Given this list of marker genes Fut9, Nkapl, Kalrn, Pan3, Pou3f2, Thoc1, Eif1ad19, Slc5a3, Pkp1, Pcmtd1, Srek1, Xlr, Clcf1, Gm20604, Sra1, 4933434E20Rik, Rap2c, Zdhhc21, Orc4, Arhgap20, Rlim, Ctdp1, Socs7, Dusp2, Nudt11, Foxo1, Asrgl1, Slc39a14, Bicd1, Atp2a2, Megf10, Sgms1, Stxbp1, Fbxw28, Rap1gap2, Zfp367, Taf3, Slc35g2, Gkap1, U2surp, Rai14, Slc26a4, Cadm1, Sntg1, Cuedc2, Lrp2bp, Tenm4, Tmem260, Speer4a2, Vamp4, C1d, Wdr1, Galnt3, Nfe2l2 (nuclear factor, erythroid derived 2, like 2), Gucy2c, Dynlt3, Gpbp1, Slc30a4, Birc6, Pclo, Nipsnap1, Abi1 (NCBI Gene Id 214715), Bmpr2 (bone morphogenetic protein receptor type 2), Kbtbd4, Stmn2, Naa15, Abtb3, Nkap, Tm2d2, Bcas2, Hsdl2, Nphs2, Cttnbp2nl (CTTNBP2 N-terminal like), Clcc1, Pak5, Mgat2, Gm10220, Reln, Snapin, Tox (NCBI Gene Id 76569), Tafa4, Zbtb5, Frmd4a, Catspere2, Rnf214, Trim66, Timp2, Dnajc1, Ms4a6b, Mbtps2, Cfap300, Pik3ca, Klk10, Ms4a6c, Arf6 (ADP-ribosylation factor 6), Mpzl1, Ube2d3, Zfp93, Pwwp3b, Slco1a4, Crebl2, Prl7d1, Phip, Adamts3, Pdss1, Med13l, Samd4, Cpeb2, Rapgefl1, Hycc2, Lrp3, Atp11a, Man1a2, Col5a1, Spry1, Epha6, Arid4a, Cdkn2aip, Speer4a1, Smim10l1, Col19a1, Adgrl3, Adamts19, Cd47, Map2, Amd2, Amer2, Rab37, Ablim1, Bpnt2, Tead1, Gm5141, Htr1a, Nid1, Triqk, Nfib, Slitrk6, Cacnb4, Clspn, Kdm3a, Uba3, Usp9x, Gnal, Tut4, Kif16b, Tafa1, Abr, Wdfy3, here is a description of the gene set: from publication Chen Y, Wang X (PMID 31504780) studied in species Mus musculus Mouse Gene Set: MIR_544_3P Genes predicted to be targets of miRBase v22 microRNA mmu_miR_544_3p in miRDB v6.0 with MirTarget v4 prediction scores > 80 (high confidence targets).